The following is a description of a gene set: studied in species Mus musculus Mouse Gene Set: CUI_B_CELL_LIF_RESPONSE_UP from publication Cui A, Huang T, Li S, Ma A, Pérez JL, Sander C, Keskin DB, Wu CJ, Fraenkel E, Hacohen N (PMID 38057668) Genes positively differentially expressed in cell type: B cell upon treatment with cytokine: LIF in mouse lymph nodes in vivo. Cytokines mediate cell-cell communication in the immune system and represent important therapeutic targets. A myriad of studies have highlighted their central role in immune function, yet we lack a global view of the cellular responses of each immune cell type to each cytokine. To address this gap, the authors created the Immune Dictionary, a compendium of single-cell transcriptomic profiles of more than 17 immune cell types in response to each of 86 cytokines (>1,400 cytokine-cell type combinations) in mouse lymph nodes in vivo. A cytokine-centric view of the dictionary revealed that most cytokines induce highly cell-type-specific responses. For example, the inflammatory cytokine interleukin-1β induces distinct gene programmes in almost every cell type. A cell-type-centric view of the dictionary identified more than 66 cytokine-driven cellular polarization states across immune cell types, including previously uncharacterized states such as an interleukin-18-induced polyfunctional natural killer cell state., and this is the list of marker genes: Med10, Zfp36l2, Klhl6, Kxd1, Lamtor4, Rbm3, Atp5f1b